The following is a description of a gene set: Acetoacetate, beta-hydroxybutyrate, and acetone collectively are called ketone bodies. The first two are synthesized from acetyl-CoA, in the mitochondria of liver cells; acetone is formed by spontaneous decarboxylation of acetoacetate. Ketone body synthesis in liver is effectively irreversible because the enzyme that catalyzes the conversion of acetoacetate to acetoacetyl-CoA is not present in liver cells.<P>Ketone bodies, unlike fatty acids and triglycerides, are water-soluble. They are exported from the liver, and are taken up by other tissues, notably brain and skeletal and cardiac muscle. There, they are broken down to acetyl-CoA which is oxidized via the TCA cycle to yield energy. In a normal person, this pathway of ketone body synthesis and utilization is most active during extended periods of fasting. Under these conditions, mobilization and breakdown of stored fatty acids generates abundant acetyl-CoA acetyl-CoA in liver cells for synthesis of ketone bodies, and their utilization in other tissues minimizes the demand of these tissues for glucose. species: Homo sapiens part of: Metabolism of lipids Reactome Pathway: Ketone body metabolism, and this is the list of marker genes: OXCT2, BDH1, BDH2, HMGCS2, AACS, HMGCL, ACAT1, ACSS3, OXCT1, HMGCLL1